Given this list of marker genes UQCRH, LYRM2, SCO2, HIGD1C, NDUFV1, COX7C (cytochrome c oxidase subunit 7C), NDUFA5, MDH1, TTC19, OXA1L, COX19, TRAP1, UQCC3, NDUFAF5, COX4I1, NDUFAB1, COX7B, ETFA, ISCU, SMIM20 (small integral membrane protein 20), NDUFAF7, COX4I2, COX14, NDUFS5, RAB5IF, COQ10A, NDUFB4, NDUFC1, NDUFAF4, MT-ND6 (mitochondrially encoded NADH:ubiquinone oxidoreductase core subunit 6), TACO1, COX8C, COX15, NDUFS4, PET117, NDUFA7, HSPA9, NFS1, COA3, NDUFS3, UQCR10, NDUFAF1, CYCS, NDUFS6, MT-CO1, MDH2, ECSIT, MT-ND4, NDUFA12, UQCRHL (ubiquinol-cytochrome c reductase hinge protein like), NDUFA11, COX17, UQCC6, COA5, SFXN4, MT-ND2, NDUFB6, NDUFB8, PNKD, COX6C, NDUFA6, SDHA, COX6B2, UQCC5, NDUFA9, UQCC2, SCO1, TMEM177, HIGD1A, NUBPL, HIGD2A, COX6A2, MT-ND3, DMAC1, NDUFA8, NDUFAF2, PET100, TMEM223, TMEM126A, UQCRC2, LYRM4, COX7A1, COX6B1, TIMMDC1, MT-ND1, CYC1, TMEM126B, NDUFB2, COX18, SLC25A11, COQ10B, NDUFS7, SLC25A18, COX5B, ETFDH, NDUFB3, NDUFC2, UQCRQ, NDUFAF6, GOT2, LETM1, COX6A1, BCS1L, MT-CYB, UQCR11, COX8A, COA1 (NCBI Gene Id 55744), SDHB, COX20, NDUFS1, LYRM7 (LYR motif containing 7), NDUFA4, CMC1, NDUFA3, UQCRC1, NDUFA1, NDUFB5, MT-ND5, MT-CO3, COX7A2 (cytochrome c oxidase subunit 7A2), NDUFB7, NDUFA2, ETFB, COX5A, NDUFAF3, COX11, HCCS, NDUFV2, FXN, UQCC1, COX7A2L, SURF1, DMAC2, UQCRB, NDUFB10 (NCBI Gene Id 4716), SLC25A13, NDUFA13, NDUFB11, NDUFAF8, SLC25A22, HSCB, ACAD9, NDUFB1, MT-CO2, GOT1, PYURF, COX16, NDUFB9, NDUFA10, NDUFV3, UQCRFS1, NDUFS8, FOXRED1, NDUFS2, SDHD, SDHC, SLC25A12, TIMM21, TMEM186, here is a description of the gene set: Respiratory electron transport studied in species Homo sapiens Human Gene Set: REACTOME_RESPIRATORY_ELECTRON_TRANSPORT